The following is a description of a gene set: Moderate reduction of the ability to see. On the 6m visual acuity scale, moderate reduction is defined as less than 6/18 but at least 6/60. On the 20ft visual acuity scale, moderate reduction is defined as less than 20/70 but at least 20/200. On the decimal visual acuity scale, moderate reduction is defined as less than 0.3 but at least 0.1. species: Homo sapiens Moderately reduced visual acuity Human Gene Set: HP_MODERATELY_REDUCED_VISUAL_ACUITY, and this is the list of marker genes: CNGB3, PIGA, IMPG1, RAC1, OPA1 (NCBI Gene Id 4976), IMPG2, LRP5, RPGRIP1, DNM1L